The following is a description of a gene set: Any process that activates or increases the frequency, rate or extent of the chemical reactions and pathways resulting in the formation of nucleotides. species: Mus musculus Mouse Gene Set: GOBP_POSITIVE_REGULATION_OF_NUCLEOTIDE_BIOSYNTHETIC_PROCESS, and this is the list of marker genes: Tmsb4x, Bcl2l1, Eno1, Pid1, Ppara, Adcy10, Myc, Vcp, Il4, Eno1b, Prkn, Adora2b, Hnf1a, Stat3, Nos3, Ndufc2, Trem2, Map2k1, Slc25a12